Given this list of marker genes TAS2R60 (taste 2 receptor member 60), PPP1CA, CXCR1, RGS4, UCN, EGFR, MLN, S1PR3, AVPR1B, FZD6, GNA15, PTH1R, ADCY1, CCL23, GRM5, TIAM1, ARHGEF18, TAS2R7, GRK5, ADRA1B, CNR2, TAS1R3, SSTR3, SRC, UCN2, TAS2R8 (NCBI Gene Id 50836), RHOA, HRH2, FFAR2, DGKQ, CXCL16, DGKI, PLPPR2, NPS, ROCK1, GALR2, PTCH1, TACR2, DGKA, NMBR, CRHR1, IAPP, WNT16, PRKACB, RGS8, CXCL10, VAV1, SSTR2, FGD3, GPR31, GPER1, PDPK1, ECE2, PTH2, CX3CR1, MLNR, BRS3, PRKAR1B, TAS2R10, SHC1, OPN1LW, GALR3, SHH, GPR35, DGKE, WNT4, PDE2A (NCBI Gene Id 5138), ROCK2, ADM2, PIK3R6, CXCL12, P2RY10, DRD2, DRD5, MC4R, CCR4, CDC42, GCG, CREB1, MC1R, WNT10B, GHRL, MAPK3, WNT6, VIPR2, GNG12, CXCR4, PCP2, GNA14, CCL25, TRHR, GPR37L1, UCN3, CXCL11, ARHGEF15, RXFP1, TBXA2R, GNB2 (NCBI Gene Id 96628), GNB5 (NCBI Gene Id 82962), CRHR2, NRAS, FN1, NPY4R, ADCY3 (adenylate cyclase 3), CCL11, PIK3R2, TAS2R1, FPR1, RGS14, PROKR2, RGS5, PTAFR, RAMP1, GRM2, CCL4 (C-C motif chemokine ligand 4), RLN2, CHRM4, ARRB1, AVP, OPN3, TAAR2, VAV3, UTS2B, HTR1B (5-hydroxytryptamine receptor 1B), ADM, TAS1R2, CCR9, RGR, TAS2R50, CGA, PYY, CALCRL, CCRL2, DHH, HTR1A, DRD1, AVPR1A, CCR8, PIK3R3, WNT10A, GNAS, TAC1, ACKR1, MC2R, PRKCB (protein kinase C beta), ARHGEF11, PLPPR1, TAS2R30, OPN4, ITPR2, OXGR1, HTR1F, AKT3, ARHGEF12, OPN1SW, GRPR, LTB4R, PTGIR, CDK5, CHRM1, PRKCQ, TRH, QRFP, OPRK1, CYSLTR2, PIK3CA, PLCB2, DGKH, INSL3, XK, WNT8A, PTHLH, EDNRB, FPR3, WNT3A, P2RY4, CCR10, CHRM3, C3AR1, RXFP3, OXTR, GPR132, PDE3B, PDE11A, GNAZ, ABHD12 (abhydrolase domain containing 12, lysophospholipase), OPRD1, CXCR3 (C-X-C motif chemokine receptor 3), WNT3, ARHGEF16, PTH, AVPR2, PRKACG, CALM1, KISS1, DGKK, GNAT1, GNAQ, GPR37, RRH, ADGRE3, EDN1, RASGRF2, C5AR1, NMUR1, ABR, GNAI2, GPR32, TAS2R41, ARHGEF40, FSHR, CCR1, CCL13, SSTR1, PTGER3, AKT2, HCRT, SAA1, P2RY14, DAGLA, AGTR1, CXCL9, MC3R, RHOB, GPR55, GIPR, HTR2B, GPSM3, GNAL, SOS1 (NCBI Gene Id 7838), LPAR1, TAS2R14, PPP3CB, PLCB3, TAS2R31, ADRB2, RGS3, TRIO, KNG1, KALRN, TAS2R9, PROK2, FZD5, PNOC, TAS2R39, EDN3, MAPK1, ADRA2C, GNA13 (NCBI Gene Id 147219), FGD2, SSTR5, GNGT1, NTSR2, ITPR3, SMO, LTB4R2, NPY2R, GRP, PMCH, CCK, ARHGEF10L, ADCYAP1R1, RGS13, CCR2, ARHGEF25, WNT7B, LHCGR, ADCY9, GALR1, GNG3, ECE1, PRKCG, CASR, TAAR9, TAS2R40, GPR25 (NCBI Gene Id 2848), GPRC6A, MCF2L, ARRB2, ECT2, PLEKHG5, GNRHR, CCL4L2, PDE7B, LPAR4, EDNRA (NCBI Gene Id 1909), VIPR1, AKAP13, CCL19, DAGLB (NCBI Gene Id 221955), IHH, PSAP (NCBI Gene Id 83009), RGS11, F2R, TAS1R1, P2RY2, PTGER2 (NCBI Gene Id 63381), RPS6KA3, DGKG, AHCYL1, TAAR8, GNB3, RGS2 (NCBI Gene Id 5997), EDN2, GLP1R, CCR7, NMB, PIK3R5, GAL, GNG4, GIP, GPR68, RPS6KA2, CD55, P2RY11, GPR150, GNG2, CAMK2D, CCR6, P2RY1, GPR143 (NCBI Gene Id 4935), FSHB, MC5R, FFAR4, MTNR1A (melatonin receptor 1A), CCL7, PRKAR2B, LPAR6, RAMP2, GPR183, MGLL, NPSR1, POMC, S1PR2, F2RL1, GPR65, CMKLR1, RGS20, WNT2, TACR3, GPR39, PTGER4, AGTR2, ITPR1, PDE3A, PRKCD, PRLH, TAS2R42, NET1, TSHR, PPP2R5D, GNAI3, HCAR3, CCL5, CCL28, TAS2R4, GPR15, GPR84, HCRTR2, PTGDR, CYSLTR1, CXCL5, PDYN, CXCL3, GNA11, UTS2, RGSL1, ANXA1, CCL1, PDE4B, OPN5, CCL2, CX3CL1, GRM4, PRKACA, CCL17, GNAT3, BTK, GPHB5, PPP3CA, GHRH (NCBI Gene Id 2691), RGS22, KISS1R, ADRA2B, FZD1, ARHGEF10, RGS1 (NCBI Gene Id 5996), ADORA2A, GRM3, LHB, PPP3R1, FZD10, DRD3, PPP2R1A (NCBI Gene Id 5518), PLPPR4, TAS2R16, PDE1A, TSHB, WNT1, GPR45, TRPC3, LPAR5, GNRH2, GRM8, PLXNB1, RGS17, PENK, PLPPR3, MCHR1, GRM1, FZD4, CRH, MMP3, CXCL8, PDE1B, CNR1, PPY, GAST, CXCL6, RGS12, MAPK7, GNAT2, CHRM5, GCGR, PTCH2, C5, KRAS (KRAS proto-oncogene, GTPase), C3, CALCB, GRK2, GNB4, SCTR, ITGA5, TAC3, ARHGEF17, NBEA, PRKX, ARHGEF38, DRD4, PDE1C, ADGRE1, GNGT2, CXCL1, ARHGEF26, HCAR2, HRAS, GRB2, F2RL2, CORT, OXT, TAS2R5, ADRA2A, PRKAR1A, TAS2R38, GNG8, RAMP3, ITSN1, HRH1, PDE4A, PPBP, PPP2CA, ARHGEF4, ACKR4, RHOC, CCR3, S1PR5, ARHGEF2, ARHGEF33, NPY, FZD8, CRHBP, GLP2R, PROK1, BDKRB2, GPSM2, TRPC6, SSTR4, ADCYAP1, TAS2R13, PIK3R1, PRKCA, PRKCH, GPR83, F2, PTH2R, DGKD, CCL20, PLCB1, ADGRE5, HTR1D, RXFP4, WNT9B, NPY5R, RGS7, TAAR1, APP, FFAR3, PREX1, NPBWR2, NLN, XCL2, F2RL3 (NCBI Gene Id 9002), APLN, AKT1 (NCBI Gene Id 207), ARHGEF39, CCL3L3, ADORA1, TAS2R19, TAS2R43, GPR176, NMS, RGS9, RXFP2, GNG10, PPP1R1B, RGS18, HCAR1 (NCBI Gene Id 94013), ITGB1, OPN1MW, CAMK4, S1PR4, PDE8B, PLEKHG2, HCRTR1, RGS10, GNG11, GPR18, ARHGEF19, HTR5A, SST, WNT7A, DGKZ, PTGDR2, CXCR5, GNRH1, GHSR, ADRB1, HTR7, TIAM2, ADCY7, PPP2R1B (protein phosphatase 2 scaffold subunit Abeta), SUCNR1 (succinate receptor 1), P2RY12, CCL16, ADCY2, FGD1, TAAR5, PLA2G4A, ADORA2B, ARHGEF1, ARHGEF35, CCKAR, GRM7, GPBAR1, SCT, HTR2A, ACKR2, ADCY5, QRFPR, LPAR2, NPBWR1, HTR6, GNG7, CHRM2, GNA12, CCL3, WNT11, TAS2R46, ADRA1D, ADCY4, NTS, HTR2C, CALCR, RGS19 (regulator of G protein signaling 19), FZD2, GNB1, GNAI1, RASGRP2, ADCY6, GPR20, INSL5, OPRL1, PDE7A, PTGER1, PDE10A, FGD4 (FYVE, RhoGEF and PH domain containing 4), HBEGF, MCF2, PLCB4, ADCY8, FZD7, AGT, UTS2R, ARHGEF6, GPHA2, OPRM1, PROKR1, HRH3, CAMKK2, CAMK2A, FZD9, GPR17, OXER1, CAMKK1, NPY1R, PPP3CC, RGS16, NMUR2, PPP2CB, GNG13, MCHR2, PF4, NMU, GRK3, ARHGEF7, NPFFR1, PRKCE, TAS2R20, CXCR2, FPR2, ARHGEF5, XCL1, C5AR2, RASGRP1, GRK6, TACR1, ARHGEF3, PAK1, GNG5, CXCL13, NPB, TAAR6, RLN3, KEL, XCR1, P2RY6, CCL27, WNT8B, HTR1E, ARHGEF37, ADGRE2, GPR4, ARHGEF9, CAMK2B, LPAR3 (lysophosphatidic acid receptor 3), GRM6, CCR5 (NCBI Gene Id 727797), PIK3CG, HEBP1, DGKB, GABBR1, ADRB3, PRLHR, OBSCN, APLNR, NTSR1, TRPC7, NPFF, GHRHR, VIP (vasoactive intestinal peptide), RGS21, WNT2B, PDE4C, CALCA, NPFFR2, FZD3, RPS6KA1 (NCBI Gene Id 6195), HRH4, S1PR1, RHO, RGS6, CXCL2, CCL22, CCKBR, FFAR1, WNT5A, ADRA1A, WNT9A, CAMK2G, GABBR2, NGEF, SOS2, PTGFR, GPR27, HTR4, PRKAR2A, KPNA2, ABHD6, NPW, PLPPR5, BDKRB1, P2RY13, VAV2, ADORA3, MTNR1B, PDE4D, GPSM1, CXCR6, ACKR3, TAS2R3, CCL21, PDE8A, here is a description of the gene set: Human Gene Set: REACTOME_SIGNALING_BY_GPCR Signaling by GPCR species: Homo sapiens